The following is a description of a gene set: Cone/cone-rod dystrophy species: Homo sapiens Human Gene Set: HP_CONE_CONE_ROD_DYSTROPHY, and this is the list of marker genes: CFAP410, BBS12, CEP19, BBS10, MKS1, RAX2, PCYT1A, BBS2, ALMS1, BBS4, PIBF1, BBS5, BBIP1, PDE6C, WDPCP, HMX1, ALPK1, PDE6H, PROM1 (prominin 1), IFT74, ATXN7, CFAP418, BBS9, TTC8, KCNV2 (NCBI Gene Id 169522), SCLT1, GUCA1A, MKKS, SCAPER, ABCA4, ADAM9, RAB28, CACNA2D4, SLC19A2, RPGRIP1, BBS1, GUCY2D, TRIM32, CACNA1F, LZTFL1, CEP290, SDCCAG8, NGLY1, TTLL5, AIPL1, CRX, PITPNM3, BBS7, IFT27, CNNM4, UNC119 (NCBI Gene Id 9094), POC1B, IFT172, ARL6, NPHP1